The following is a description of a gene set: part of: Antimicrobial peptides studied in species Mus musculus Reactome Pathway: Defensins electronically inferred by orthology from the curated human pathway This event has been computationally inferred from an event that has been demonstrated in another species.<p>The inference is based on the homology mapping from PANTHER. Briefly, reactions for which all involved PhysicalEntities (in input, output and catalyst) have a mapped orthologue/paralogue (for complexes at least 75% of components must have a mapping) are inferred to the other species., and this is the list of marker genes: Defa23, Prss3, Defb42, Defb25 (defensin beta 25), Defa3 (NCBI Gene Id 13237), Defa32, Defa42 (defensin, alpha, 42), Defa17, Defa28, Ccr6, Defa38, Defb3, Defa31, Defb21, Tlr2, Defb18, Defb48, Defa43, Defa26, Defa21, Defa34, Tlr1, Defb36, Try10, Defa35, Defa20, Defb43, Defb14, Defa39 (defensin, alpha, 39), Defb28, Prss2, Defb47, Defa25, Defa24, Defa36, Art1, Defa37, Defb1, Defa30, Defb19, Defa41